The following is a description of a gene set: species: Homo sapiens Perifoveal ring of hyperautofluorescence Human Gene Set: HP_PERIFOVEAL_RING_OF_HYPERAUTOFLUORESCENCE, and this is the list of marker genes: TTLL5, PRPH2, PRPF31, TLCD3B, PROM1, CFI, IFT172, KLHL7, EFEMP1, GUCY2D, PRPF8, AIRE, MFSD8 (NCBI Gene Id 256471), GUCA1A, RAX2, CFH